Given this list of marker genes Slamf6, Cryzl2, Adamts4, Rab17, Cd48, Apcs, Odr4, Tmem183a, Sned1, Tlr5, B4galt3, C130074G19Rik (NCBI Gene Id 226777), Cfap126, Rgs7, 3110009E18Rik, Zranb3, Actr3 (ARP3 actin-related protein 3), Spta1, Prg4, Tatdn3, Fam20b, Rab3gap1, Cd244a, Dusp12, Pcp4l1, Tstd1, Ivns1abp, Dusp23, Capn10, Cdh19, Uap1, Uchl5, Tor1aip1 (torsin A interacting protein 1), Usf1, Lrrfip1, Sdhc, Fmn2, Apoa2, Bpnt1, Scly, Igsf8 (NCBI Gene Id 98593), Lad1, Copa, Mtarc1, Ifi214, Pigm, Nme7, Pign, Nav1, Hsd17b7 (hydroxysteroid (17-beta) dehydrogenase 7), Soat1, 2310009B15Rik, Tmem37, Vps4b, Mlph, Ppfia4, Marco, F11r, Fcgr2b, Ptprv, Nit1, Cyb5r1, Cenpl, Mab21l4, Fcer1g, Plxna2, Rabgap1l, Smyd2, Ifi208, Ppox, Insig2, Grem2, Agxt, Slc35f5, Dars2, Kmo (NCBI Gene Id 98256), Rgs18, Slc30a1, Rps6kc1, Mrps14, Klhdc9, Ifi202b, Fmo4 (flavin containing monooxygenase 4), Gas5, Hes6, Itln1, Fmo1, Cfhr1, Tsen15, Iars2 (isoleucine-tRNA synthetase 2, mitochondrial), Ddr2, Ifi204, 2810025M15Rik, Dbi, Dcaf8, Rgs5, Glrx2, Nenf (neuron derived neurotrophic factor), Cep170, here is a description of the gene set: Mouse Gene Set: CHEN_LIVER_METABOLISM_QTL_CIS from publication Chen Y, Zhu J, Lum PY, Yang X, Pinto S, MacNeil DJ, Zhang C, Lamb J, Edwards S, Sieberts SK, Leonardson A, Castellini LW, Wang S, Champy MF, Zhang B, Emilsson V, Doss S, Ghazalpour A, Horvath S, Drake TA, Lusis AJ, Schadt EE (PMID 18344982) species: Mus musculus Cis-regulated expression quantitative loci (cis-eQTL) in the liver that contribute to metabolic quantitative traits (weight, fat mass, and plasma glucose and cholesterol levels). Identifying variations in DNA that increase susceptibility to disease is one of the primary aims of genetic studies using a forward genetics approach. However, identification of disease-susceptibility genes by means of such studies provides limited functional information on how genes lead to disease. In fact, in most cases there is an absence of functional information altogether, preventing a definitive identification of the susceptibility gene or genes. Here we develop an alternative to the classic forward genetics approach for dissecting complex disease traits where, instead of identifying susceptibility genes directly affected by variations in DNA, we identify gene networks that are perturbed by susceptibility loci and that in turn lead to disease. Application of this method to liver and adipose gene expression data generated from a segregating mouse population results in the identification of a macrophage-enriched network supported as having a causal relationship with disease traits associated with metabolic syndrome. Three genes in this network, lipoprotein lipase (Lpl), lactamase beta (Lactb) and protein phosphatase 1-like (Ppm1l), are validated as previously unknown obesity genes, strengthening the association between this network and metabolic disease traits. Our analysis provides direct experimental support that complex traits such as obesity are emergent properties of molecular networks that are modulated by complex genetic loci and environmental factors.